Given this list of marker genes CCDC66, RABGEF1P1, DGKE, DPY19L2P2, RNF125, CFAP36, VPS37A, S100A10, PLEKHA7, BCL2L13, CDKN1B, IQCH-AS1, NR1D2, LITAF, NAP1L2, POLR3E, VSIG1, HACD1, TRABD2A, PAIP2B, PPP1R26-AS1, CAPN3, DCBLD1, MED6, RNPC3, RUNDC3B, AASS, CDC42SE1, ARHGEF17, TOB1, MICA-AS1, TSPO, GLUD2, CDK5RAP1, NCLN, IDS, RAB11FIP3, SYNJ2BP, UBP1, ACVR2A, ABCA3, TARS3, ABHD14A, CFAP70, ATMIN, DUSP16, MICAL3, SEMA4D, KIF21A, HLA-DPA1, TNFRSF10B, LIG1, MORC4, LONRF3, KIF5C, C9orf72, CDC37L1, PRRT1, SLC22A17, GATAD1, STAM, C2orf88, LIAS, PAPLN, POLR3F, NIFK-AS1, TRIM7, ERN1, TXNDC2, ADAT1, SLC16A6, BLOC1S3, EML4 (NCBI Gene Id 54548), SLC46A1, KRT35, NFYB, IL6R, SLC13A4, LCORL, TTC39C, PURA, CACNA1I, OXNAD1, KLHL6, KMT2E-AS1, MRFAP1L2, KAT6A, OGA, FGF9, KLF9, MYLIP, DUSP12, ABCG1, HSBP1L1, KNCN, ARHGEF12, MTSS2, IRS2, LIMK2, ADAM12, SPAG9, ZNF204P, ZNF287, LRP11, TMEM154, SRSF7, LINC00294, SETD7, LRRC8C, KALRN, TAGAP, CCL28, CELF2, TUBGCP5, ZNF532, SEMA3G, PIK3C2A, LINC01550, KIF5A, CGRRF1, NEAT1, BCORP1, ZNF548, DTX4, TXLNGY, SPTAN1, C14orf28, PLA2G12A, PTCH1, RPL21, MAPKAPK5-AS1, ANKS1B, TATDN3, HTRA4, TXNIP, MS4A1, ATG16L1, SORL1, SELP, TRAPPC13, FXYD5, ACSM3, ZNF782, NFATC2, PKP4, SNHG28, BBS4, PATJ, POU6F1, ARHGAP12, ZFP36L2, FZD4, SNHG10, RORA, KCNA3, OCM2, TGM4, COQ10A, ENO2, DUSP18, F2RL2 (coagulation factor II thrombin receptor like 2), LILRA6 (leukocyte immunoglobulin like receptor A6), RADX, UBASH3B (NCBI Gene Id 84959), MATN1-AS1, FKBP11, NTSR2, RIPOR2, CEP85L, LASP1NB, CCR6, NFIA, BACE1, EOGT, FOSL2, CNPY3, PPP1R2, GUSBP4, OPHN1, ACSL5, SARAF, FOXP1, OSTM1, KLF12, C12orf42, SLC25A4, ADCY1, SIRT1, ITK (IL2 inducible T cell kinase), CDHR3, PCSK7, ASAH1, HECA, here is a description of the gene set: We compared differences in fetal and adult T cells by performing whole genome profiling on sort-purified T cells (naïve CD4+ and Treg cells) from human fetal specimens (18-22 gestational weeks) and adult specimens (age 25-40 years old). Fetal and Adult Naïve CD4+ T cells phenotype: CD3+CD4+CD45RA+CCR7+CD27+, Fetal and Adult CD4+CD25+ Treg phenotype: CD3+CD4+CD25bright studied in species Homo sapiens Human Gene Set: GSE25087_FETAL_VS_ADULT_TREG_DN from publication Mold JE, Venkatasubrahmanyam S, Burt TD, Michaëlsson J, Rivera JM, Galkina SA, Weinberg K, Stoddart CA, McCune JM (PMID 21164017) Genes down-regulated in comparison of fetal regulatory T cell (Treg) versus adult regulatory T cell (Treg).